The following is a description of a gene set: Any process that contributes to cytokine production by a dendritic cell. Human Gene Set: GOBP_DENDRITIC_CELL_CYTOKINE_PRODUCTION studied in species Homo sapiens, and this is the list of marker genes: TLR9, DDX1, TLR4, PLCG2, RIGI (RNA sensor RIG-I), TLR3, SCIMP, CLEC7A, JAK3, TICAM1 (NCBI Gene Id 148022), CAMK4, MAVS, DDX21, NOD2, BST2, KIT, DHX36